The following is a description of a gene set: CD4+ T cells that selectively produce interleukin (IL)-17, are critical for host defense and autoimmunity1-4. Crucial for T helper17 (Th17) cells in vivo5,6, IL-23 has been thought to be incapable of driving initial differentiation. Rather, IL-6 and transforming growth factor (TGF)-β1 have been argued to be the factors responsible for initiating specification7-10. Herein, we show that Th17 differentiation occurs in the absence of TGF-β signaling. Neither IL-6 nor IL-23 alone efficiently generated Th17 cells; however, these cytokines in combination with IL-1β effectively induced IL-17 production in naïve precursors, independently of TGF-β. Epigenetic modification of the Il17a/Il17f and Rorc promoters proceeded without TGF-β1, allowing the generation of cells that co-expressed Rorγt and T-bet. T-bet+Rorγt+ Th17 cells are generated in vivo during experimental allergic encephalomyelitis (EAE), and adoptively transferred Th17 cells generated with IL-23 in the absence of TGF-β1 were more pathogenic in this experimental disease. These data suggest a new model for Th17 differentiation. Consistent with genetic data linking the IL23R with autoimmunity, our findings re-emphasize the role of IL-23 and therefore have important implications for the development of new therapies. Human Gene Set: GSE23505_UNTREATED_VS_4DAY_IL6_IL1_TGFB_TREATED_CD4_TCELL_DN Genes down-regulated in CD4 T cells: untreated versus IL6 and TGFB1. species: Homo sapiens from publication Ghoreschi K, Laurence A, Yang XP, Tato CM, McGeachy MJ, Konkel JE, Ramos HL, Wei L, Davidson TS, Bouladoux N, Grainger JR, Chen Q, Kanno Y, Watford WT, Sun HW, Eberl G, Shevach EM, Belkaid Y, Cua DJ, Chen W, O'Shea JJ (PMID 20962846), and this is the list of marker genes: DPP4, DMWD, TARS2, STK4, RNF149, NISCH, TMEM230, EXOSC5, SH3RF1, CDK5R1, ADAMTS8, DAG1, PRXL2B, MAML1, MBOAT7, BAG3, ZNF518A, PDE6D, ANKRD54, TMEM200A, MIGA1, YPEL3, CBR1, ZNF217, ACTG2, SYT11, C11orf71, ACSL3, TPP1, TMEM63B, FAM120B, ARID4A, MSI2, RCL1, PACRGL, ZXDC, DYNLT3, MOV10, ZNF799, ACAT1, UTRN, MTFMT, BTRC, AGBL5, C11orf68, GNL1, PAM, RAB11B, ADAMTS6 (ADAM metallopeptidase with thrombospondin type 1 motif 6), INPP5K, CCPG1, ACP2, NOXO1, NLK, NLRP6, EARS2, RASGRP1, PCDHB12, ISCU, CAMK2D, ABCC5, EGR3, EIF4B, CNOT6L, RABL3, MAP1B, TNC, SMAD4 (SMAD family member 4), RMND1, CHMP1A, FIBP, FGF13 (fibroblast growth factor 13), SESTD1, KDSR, STK40, WDR11, SDHAF1, TMEM87B, RNF19A, SREK1, COQ8B, SUFU, TIRAP, BCKDHA, ZNF24, TTC33, TCF12 (transcription factor 12), POLR1C, ESAM, WDR77 (WD repeat domain 77), CYB5A, MYCBP2, TEF, BMI1, TRIM21, BAG4, UBAC2, SNHG8, MFSD4A, CNP, RYK, ROMO1, FHIP1A, PIGX, FAM98C, ECI2, CFAP410, GLG1, IPO8, LSM14B, WDR12, PIGY, ARHGAP45, ABCC4, RNF41, GPATCH4, TBC1D32, ZCCHC12, CDKAL1, DDX42, EME2, RPS25, MANBA, TMEM191C, EZH1, DBP, PGPEP1, RPL13, LACTB, ZFAND1, IL27RA (NCBI Gene Id 9466), MIB1, TLCD1, QSOX2 (quiescin sulfhydryl oxidase 2), USP6NL, OAS1, ZNF329, NINJ1, TGIF2, ASH1L, MMP11, ACBD4, CCDC62, CXCL10, METTL27, AKR7A2, CUL4A, ANKZF1, CYB5D2, ANGPTL8, OPA1, BPHL, VPS41, CERS6, STK26, PER1, DNAJA3, IKBIP, LRP6, TGIF1, HIF1A, NUDT12, B3GNT2, NFKBIE, NDST2, RNF128, QTRT1, ACOX1, ALKBH4, ST3GAL1, TNF, RSAD2, GTF2H3, DHX34 (NCBI Gene Id 9704), RFESD, KIF5C, CCDC117, AGPAT5, CFAP418, NUMA1, HAGHL, PLEKHA8, PHF23, USP19, ZNF623, TRAF1, CASP6, RNF139, HMG20A, TNS1, CSTB, TSACC, SOX4, LDHB, CEP19, SLC14A1 (NCBI Gene Id 6563), ADIPOR2, JARID2, MAP2K5, SERINC5